The following is a description of a gene set: Catalysis of the reaction: acetyl-CoA + histone H4 L-lysine (position 5) = CoA + histone H4 N6-acetyl-L-lysine (position 5). species: Mus musculus Mouse Gene Set: GOMF_HISTONE_H4K5_ACETYLTRANSFERASE_ACTIVITY, and this is the list of marker genes: Brpf3, Taf1, Crebbp, Hat1, Kat6b, Jade2, Kat6a, Ncoa1, Ncoa3 (NCBI Gene Id 99361), Meaf6, Mcm3ap, Kat2b, Brd1, Kat5, Ep300, Nat8f3, Cdyl, Kat7, Naa60, Ing4, Gtf2b, Clock, Brpf1, Ing3, Kat2a, Nat8f7, Jade1, Gtf3c4, Kat8